Given this list of marker genes Bnip3, Erbb4, Bax, Prkn, Mff, Atg3, Ccar2, Dnm1l, Fis1, Ppp2r2b (protein phosphatase 2, regulatory subunit B, beta), Nptx1, Vps35, here is a description of the gene set: The change in the morphology of the mitochondria in an apoptotic cell from a highly branched network to a fragmented vesicular form. species: Mus musculus Mouse Gene Set: GOBP_MITOCHONDRIAL_FRAGMENTATION_INVOLVED_IN_APOPTOTIC_PROCESS